Given this list of marker genes ZNF799, MAP3K11, ARID5A, TNFSF10, TEX14, EHD4, PSORS1C3, ANGPTL2 (angiopoietin like 2), SHFL, WHAMM, IL15, PI4K2B, TYW1B, KCNQ4, NFKB2 (nuclear factor kappa B subunit 2), PLEKHF2, RP2, LY6E, WNT4, TESK2, HSPA6, SLC25A30, CBR3, HLA-H, OASL, HCAR3, TGM5 (transglutaminase 5), NCOA7, CIMAP1B, MRGPRX3, RASSF10, MLKL, IMPA1, CFAP45, ADAMTS15 (NCBI Gene Id 219807), ATP10A, CARD8-AS1, PHACTR4, SIRPB2, TTC38, USF1, SP8, BST2, KLHDC7B, NFKB1, FAM43A, SOX13, CLDN16, ARSI, DUSP2, C17orf67, GNB4 (NCBI Gene Id 59345), MARCKSL1, ULBP1, PALM, HSD11B2, TRIM26, HES4, CFLAR, PLAUR (NCBI Gene Id 5329), PPM1K, SECTM1, GALM, ADM, ADAR, PPM1J, UBE2L6, ADCY4, IFIT5, PHF11, ZBTB42, PARP9, AVIL, ANTXR2, TMEM106A, OVOL1, TLR2, KRT6B, NFKBIA, ZNFX1, EDARADD, TIPARP, TRIM21, ST7-AS1, GPR37, FHL3, CDKN2C, STAT5A, ALAS1, TICAM1, PRDM8, FAM222A, CDK17, SAMHD1, IL1A, JUNB (NCBI Gene Id 90482), SLC2A12, FAM53C, TNFAIP8L3, LYPLA1, IRF1, DUSP8, ABCD1, APOL1, B2M, OSR2, SP6, ID4, ZNF136, SLC25A28, RNF213, ELF1, NFKBID, SPRY2, HERC6 (NCBI Gene Id 55008), B3GALNT1, FMR1, ID2, HSH2D (hematopoietic SH2 domain containing), NFE2L3, TNFSF9, ERG, PTGER2, SLC8B1, SWT1, IFNL4, C2CD4A, IRF6, DAPP1, TRIM36, SLC8A2, RIPK2, ITIH4, SOX21, CARD17P, ICAM1, PSMB9, NFATC1, NT5C3A, FUT2, KLF4, GCA, PLEKHG6, SP140L, TTC39B, CCL22, VLDLR, XBP1, CASP10, KLF10, APOBEC3G, ACHE, ZNF44, GBP1, EGFLAM, IL36G, HLA-L, RICTOR, ZNF461, KRT75, C3AR1, DPP4, CCDC9, ATP5F1E, IFITM1, ARC, IFRD1 (interferon related developmental regulator 1), AZIN2, MX1, C2orf66, ACTN2, ERAP2, BATF2, H2AC25, IL15RA, GSAP, DDX60L, CDC42EP4, KCNJ15, C11orf96, ACE2, PDE4B, MORC3, GATA6, CXCL16, DNAJA1, IL7, SEPTIN4, RELL1, BMF, RTP4, CPEB3, PARP14, OAS3, CSRNP2, KBTBD7, RTKN2, APOBEC3B, IFITM2, CLIC2, TMEM229B, THAP9-AS1, SENCR, NUDCD1, ZBP1, PLEKHO2, CSF3, CYP2J2, TLE4, CARD16, SOWAHB, SNAI1, IL23A, KRT34, MUC15, DEPP1, MTMR11, RND1, APOBEC3F, HLA-A, CASP7, RAD9A, IL22RA1, NLRC5, STAT1, CXCL10, ETV7 (ETS variant transcription factor 7), USP43, RBM43, GBP3, MOB3C, SCO2, OPTN, GLRX, SLC6A12, AZI2, TNFSF13, HEXD, SLC12A7, IRF7, APOL3, EPB41L4A-DT, APOL6, IL16, TREX1, TRIM5, HDX, TRIM14, ADPRM, CMTR1, LAMA2, BTN3A1 (NCBI Gene Id 11119), PGM2L1, EXOC3L1, TMEM140, KDM7A-DT, CXCL2 (NCBI Gene Id 2920), ARL14, PGLYRP4, KLF9, MARCHF3, TINF2, LMO2 (NCBI Gene Id 8051), BMP4 (bone morphogenetic protein 4), EPSTI1, IFI30, SP110, CXorf38, FAP, CEACAM1, WARS1, SPSB1, IFITM3, CAB39, STARD5, DCLRE1C, ZC3H12A, CALHM5, NXT2, HSPB8, PTGS1, TMEM62, SHISA2, FGF5, BCL3, HES6, BBC3, BTN3A3, VASN (NCBI Gene Id 337957), ICOSLG, JUN, PRKD2, SLC5A1, CCNL1 (NCBI Gene Id 57018), TAPBP, GEM, EDN1, DLC1, SLC25A25, TENT4B, MXD1, PIK3R3, TPRN, CYLD, TYMP, KALRN, PKIB, ZNF107, IRAK2, GPBP1, H3C4, TAP1, B3GNT2, OLR1, IFIT1 (interferon induced protein with tetratricopeptide repeats 1), RASL11B, CACHD1, ZMYND15, CALCRL, BIRC2, SLC39A8, TRIM56, STX11, ADAMTS4, TRIM22, KIAA0040, DDX3X, POU3F1, BAIAP3, TNIP1, XAF1, TNFSF13B, C6orf62, LGALS3BP, ZNF267, MCUB, SIRT1, PABIR3, DUSP1, KCNK5, NEURL3, MAFA, PDCD1LG2, TRIM69, SLC52A3, IL12A, FYB1, HSPA2, CD40, SOX9, KCNS3, GNA13, UNC93B1, EPGN, TNFRSF9, CCNA1, RASGEF1B, ARRDC3, SIX1, ZCCHC2, DEPDC7, RGMB-AS1, SYNPO2, HLA-DOB, SLC35E4, CSRNP1, C1QTNF1, TBX3, CLCF1, CAVIN2, FSD1L, TNFAIP8, RNF122, MFSD14A, SAMD9L (NCBI Gene Id 4827), SLCO4A1, HELZ2, BPGM, APOL2, BTC, PRICKLE1, PARP10, CSF1, PRR15, PANX1, NECTIN3, ILDR1, HIP1R, PML, XDH, ENC1, SYNM, SUSD4, NMI, ARHGAP25, BTN3A2, WTAP, HERC5, ANKK1, HNRNPLL, REC8, PNRC1, FLT3LG, DLX5, PSMB8-AS1, HLA-C, ZFYVE26, DTX3L (NCBI Gene Id 151636), SMOX, DLX3, IGFBP3, SCN3A, SLFN12, APOBEC3A, MYD88, FAM76B, FUT4, ADAM8, CXCL5, BCL2L11, TGIF1, LIN52, LGALS9, PSMB8, SLC41A2, HCAR2, RNF223, DMRTA2, ING1, GLCCI1, FZD8, IFIT2, CORO6, PSMB10, THAP3, RASGRP3, LYSMD2, IFIT3 (NCBI Gene Id 8376), MSX2, SEMA7A, NEFM, CASP1, FA2H, OAS1, PLAT, ZNF442, TEP1, RDH10, ABHD17B, ZNF844, PLEKHA7, ZNRF2, CD38, RIMS2, PAMR1 (NCBI Gene Id 25891), SOCS3, CBX4, IFI44L, H3C10, PIK3AP1, STAT2, SLC15A3, TRIM25, KLF2, N4BP1, SP100, EPHB3, IRF2, RASEF, CITED2, AIM2, HSD17B7P2, MAFF, MIR155HG, PRICKLE4, MASTL, PLEKHF1, CGAS, LINS1, GCH1, TRIB2, HLA-F, EMC9, CDKN1C, MMP13, PLAAT2, SGK1, RIPK3, LAP3, RABGAP1L, SLC44A4, DISP3, CARINH, HAPLN3, CBR3-AS1, IKBKE, HS3ST1, PNP, RNF152, GPR180, CD83, SOCS2 (NCBI Gene Id 8835), BCL2L14, CDC42EP3, CRISPLD2, TGM2, GBP2, C1R, UBA7, RASSF5, FGF2 (fibroblast growth factor 2), NUB1, IL1R2, PARP8, PNPT1, GRB10, FBXO6, STK19, RNF114, IFI6 (interferon alpha inducible protein 6), GATA3, RGS16, MAP3K14, HLA-E, FSIP1, ZNF296, LYN, DUSP5, IL10RA, TTLL11, GRAMD2B, FIBIN, RSAD2, RBCK1, DHX58, ACTL10, TRIB1, LIF, SNPH, CLUHP3, IFIH1, TDRD7, IL1B, EDN2, SBNO2, MEF2C, SPRED3, TAGAP, C15orf39, RIGI, CEBPB, ETS2 (NCBI Gene Id 2114), LGMN, HLA-B (major histocompatibility complex, class I, B), CLIC4, IFI27, PAOX, HSPA1B, VEGFC, ELK4, TRIM38, RIPK1, OGFR, RDUR, SOCS1, SMARCA5, NOD2, MX2 (MX dynamin like GTPase 2), MUC16, IFI16, RBM11, PSME2, DENND3, SLC16A4, IRF9, PLAAT4, CNP, C1S, TMEM171, BCL2L13, TRANK1 (tetratricopeptide repeat and ankyrin repeat containing 1), ZNF503, NOD1, IER2, SLC45A4, H2BC11, HBEGF, CMPK2, BCL2A1, VEZF1, CLCA3P, TLR3, CERS3 (NCBI Gene Id 204219), EIF2AK2, RHOB, C3, SIDT1, IRX5, LINC02591, CCT6P1, METRNL, EFNA1, GRIP2, RNF39, IFI35, RCAN1, TENT2, GSDMD, ANGPTL4, STOML1, FZD5, CXCL3, FAS, SERPINB9, NPR1, OAS2, CHAC1, TAP2, THSD1, GTPBP1, VAMP1, IFI44, PLSCR4, DLX2, PPP1R3B, EDNRA, USP18, RNF19B, ZFP36, B3GNT7, FZD7, KBTBD8, HAP1, PARP12, NUAK2, RAB8B, RGMB, RET, ZNF79, RHEBL1, THEMIS2, PLSCR1, NCF2 (NCBI Gene Id 4688), AKAP7, here is a description of the gene set: from publication Blanco-Melo D, Nilsson-Payant BE, Liu WC, Uhl S, Hoagland D, Møller R, Jordan TX, Oishi K, Panis M, Sachs D, Wang TT, Schwartz RE, Lim JK, Albrecht RA, tenOever BR (PMID 32416070) species: Homo sapiens Analysis of the transcriptional response to SARS-CoV-2 compared with other respiratory viruses, including MERS-CoV, SARS-CoV-1 (SARS), human parainfluenza virus 3 (HPIV3), respiratory syncytial virus (RSV), and IAV. Human Gene Set: BLANCO_MELO_BRONCHIAL_EPITHELIAL_CELLS_INFLUENZA_A_DEL_NS1_INFECTION_UP Genes up-regulated on infection of normal human bronchial epithelial cells by mutant Influenza A lacking its antiviral antagonist (IAV_NS1) (MOI: 3, 12hpi)